Given this list of marker genes Aacs, Bdh2, Acat1, Hmgcl, Acss3, Hmgcs2, Hmgcll1, Bdh1, here is a description of the gene set: Mouse Gene Set: REACTOME_SYNTHESIS_OF_KETONE_BODIES species: Mus musculus Synthesis of Ketone Bodies